Given this list of marker genes METTL22, SMIM8, RAMAC, KLK8, ZNF579, LYPD5, COL9A3, PSME1, GRAP, AKAP9, E4F1, HNRNPAB, SUGT1, PPP1R35, SNORD104, INSC, CRTAM, MTFR1L, URM1, VPS11, MLXIP, EPS8L3, MSI2, EFNA4, PFDN6, MS4A15, DACT2, TCN2, ORAI2, ATP6V1F, ALB, MTCL3, ZNF385C, MTERF4, DBNDD2, TMEM213, RUNDC1, EGR3, BLOC1S1, CNRIP1, CD3D, IGFALS, TDRP, U2AF1, IL10RB (interleukin 10 receptor subunit beta), NFE2L1, FHIT, PIP4K2B (phosphatidylinositol-5-phosphate 4-kinase type 2 beta), KRT78, PARP6, ADGRG5, RPL14, UQCR10, RABAC1, RNF166, AP1B1, AMN, RPL26, BCL6, CCDC88B, GRAMD4, MBD3, RGS3, IKBKE, SLC22A18, AP4S1, MAX, NDUFS5, TNIP1, PHLDA3 (NCBI Gene Id 23612), RAB37, EVL, PIPOX, PLCD1, SLC37A1 (NCBI Gene Id 54020), NINJ1, NFE2L3, PHF19, KCNJ8, LSM6, BRD2, PSMD3, TTLL7, RPL41, PARP8, EEF1A2, KRT71, TAF12, PITPNM1, ZMAT5, PTBP1, PARP16, DNAJC17, SP110 (SP110 nuclear body protein), GZMM, DACH1, ATP5MC2, STS, LTB, SDF4, COTL1, TPRN, ARHGAP45, RHCG, RNF123, POU6F1, SNRPD1, SBF2, CHD3, CARD6, VPS25 (vacuolar protein sorting 25 homolog), SIT1, BBX, NDUFA7, HSD17B11, GPS2, SLC14A1, ZNF740, DDIT3, INPP1, SLC17A9, ZNF777 (zinc finger protein 777), KMT2A, PLXNB1, CBX7, ZC3H13, TRAF3IP3, RFLNB, SPAG7 (NCBI Gene Id 9552, sperm associated antigen 7), IRF7, MRPL24, SH3GL1, ATG13, FAU, NFKB2, RNF167 (ring finger protein 167), SDHC, TMEM25, GREB1, NSA2, PRSS12 (serine protease 12), GPR18, MEA1, RPL36, UBXN11 (NCBI Gene Id 91544), OGG1, TCP11L2, MAP3K3, S100A5, CRTC3, GPR132, AQP9 (aquaporin 9), NDUFA6, ITPR2, ZNF335, ZNF394, MAP3K14 (mitogen-activated protein kinase kinase kinase 14), KCNMA1, NPC1L1, IFT56, NSFL1C, IRF2BP2, KCNJ11, C2CD4B, SLC25A29, NT5E, TEF, PNRC1, YPEL3, CNR2, EIF3I, PLAAT3, PAQR7, PLD3, CAMK2G, PDE2A, RPS7, MYC, ZFP36, KAT2A, CD72, MRPS34, COX20, OPCML, ARAP1, SNORC, LCP2, IGLL1, SCAND1, PDLIM1, NLRC3, ATG16L2, TNFRSF1A, MED8, JUN, MED13L, ASPHD1, UBC, RAB11FIP1, here is a description of the gene set: Using killer cell lectin-like receptor G1 as a marker to distinguish terminal effector cells from memory precursors, we found that despite their diverse cell fates both subsets possessed remarkably similar gene expression profiles and functioned as equally potent killer cells. However, only the memory precursors were capable of making IL-2 thus defining a novel effector cell that was cytotoxic, expressed granzyme B, and produced inflammatory cytokines in addition to IL-2. This effector population then differentiated into long-lived protective memory T cells capable of self-renewal and rapid re-call responses. Mechanistic studies showed that cells that continued to receive antigenic stimulation during the later stages of infection were more likely to become terminal effectors. Importantly, curtailing antigenic stimulation towards the tail-end of the acute infection enhanced the generation of memory cells. These studies support the decreasing potential model of memory differentiation and show that the duration of antigenic stimulation is a critical regulator of memory formation Genes up-regulated in comparison of memory CD8 T cells versus effector CD8 T cells. species: Homo sapiens from publication Sarkar S, Kalia V, Haining WN, Konieczny BT, Subramaniam S, Ahmed R (PMID 18316415) Human Gene Set: GSE10239_MEMORY_VS_DAY4.5_EFF_CD8_TCELL_UP